The following is a description of a gene set: Signaling by MST1 studied in species Homo sapiens Human Gene Set: REACTOME_SIGNALING_BY_MST1, and this is the list of marker genes: MST1R, SPINT1 (NCBI Gene Id 8610), SPINT2, HPN, MST1